Given this list of marker genes H2BC12, TAF1D, H3C15, 28S rRNA, H2AC6, H2BC26, H2BC14, H2BC5 (NCBI Gene Id 3017), H2BC4 (H2B clustered histone 4), H2BC17, H2BC15, 5S rRNA, H2AC4, H2BC21, H2BC13 (NCBI Gene Id 8340), H2AC18, H3C1, TAF1A, H2AB1, H2BC3, TAF1B, SUV39H1 (SUV39H1 histone lysine methyltransferase), H2AC14, H2BC1, SIRT1 (sirtuin 1, NCBI Gene Id 23411), H2BC12L, H2AC20, H3-3A, H2AJ, TBP, H2AZ2, H2BC11, 5.8S rRNA, H2AX, RRP8 (NCBI Gene Id 23378), H4C1 (NCBI Gene Id 8359), TAF1C, H2AC7 (NCBI Gene Id 3013), H2BC9, here is a description of the gene set: Expression of rRNA genes is coupled to the overall metabolism of the cell by the NAD-dependent histone deacetylase SIRT1, a component of the Energy-dependent Nucleolar Silencing Complex (eNoSC). eNoSC comprises Nucleomethylin (NML), SIRT1, and the histone methylase SUV39H1. Deacetylation and methylation of histone H3 in the chromatin of a rRNA gene by eNoSC causes reduced expression of the gene. When glucose is low, NAD is high (NADH is low), activity of SIRT1 is high, and activity of rRNA genes is reduced. It is hypothesized that eNoSC forms on a nucleosome containing dimethylated lysine-9 on histone H3 (H3K9me2) and then eNoSC deacetylates and dimethylates the adjacent nucleosome, thus catalyzing spreading of H3K9me2 throughout the gene. species: Homo sapiens Reactome Pathway: SIRT1 negatively regulates rRNA expression part of: Negative epigenetic regulation of rRNA expression